Given this list of marker genes PDIA5, STK40, MED28, MYO1F, UBALD2, NDUFA7, ZBP1, CLCN1, IRF7, PIK3CD, GYPC, SIK3, OAS3, ZNF580, IP6K1, TTYH3 (NCBI Gene Id 80727), TMEM140, PLAC8, SERTAD3, C19orf53, NFATC2IP, PDE4B, MROH1, DNAJC7, PLAGL1, GTF3C5, DACT2, STX11, PRDX2, DSE, C1orf54, ARHGAP8, FBXO33, SPCS2, SRD5A3, TRAFD1, PAK1, PTGR1 (prostaglandin reductase 1), C9, SAA1, MCTP1, CHMP5, ADAM8, FES, CBLB, KIF13B, NDST1, USB1, PDLIM2, ENG, EVL, OTUD1, SLIT3, TMEM98, CYTH1, NBAS, ITM2C, F11R, TLR4, GCA, TAPBP, IFT22, DYNLT2B, NIT1, CDH15, TDRD7, RAB19, ITM2B, MSANTD1, IRGM, RBM43, KCNAB2, FYCO1, GMPPB, TBX21, IFNG, BLVRB, SH3BP2, IKZF2, SETDB2, STAT1, CA2, PARP8, RERE, STC2, PEX2, PTPRS, PRRC1, ZNF839, SMDT1 (single-pass membrane protein with aspartate rich tail 1), IL10RA, TLR2, IRF5, SERPINB6, PHF21A, HNRNPLL, ATOX1, IL18, SAMD12, LLGL1, OAS2, TNFSF11, C19orf38, DHX58, PARP14, AP1M2, ICOS, SOCS1, LGALS3BP, GPR18, CASP9, MOCOS, SLC9A1, NUB1, DPH5, HERC6, KCTD2, STK10, TP53BP1, SNAP47, CCL4, SPATA13, NT5C3A, MIEN1, CD86, CFAP36, NKG7, RIGI, LMCD1, WASF2, MAPKBP1, STX2, PRKCD, ATP8A1, ART5, CSF1 (NCBI Gene Id 1435), DDX60, MPPED1, QPRT, ADIPOQ, HMGA2, GCHFR, NCOA7, DTX3L, ISG20, SHFL, PCBD1, HOXB3, GNG2, RESF1, ADAMTS8, CLEC6A, ERGIC3, ACOT8, ITGA4, RNASEL, LRRC74A, ZFPM1, SLC35B4, STAT2, SPATA6, ZNF513, IGHMBP2, ZNFX1 (zinc finger NFX1-type containing 1), C15orf40, TBRG1, TEX35, FCER1G, LAMTOR4, TJP2, CSF2, EPSTI1, BBS4, MAF, SAMHD1, RTP4, DRGX, P3H1, QNG1, CGAS, CMPK2, IL2RB, RSAD2, NACC2 (NACC family member 2), MTX1, ANXA1, CCRL2, ITPR1, TRAPPC1, CXCL13, SGCB, CST3, LYN, TRIM5, DYNC2LI1, NUP210L, FKBP15, NAT1, ASAH2, here is a description of the gene set: Human Gene Set: GSE41867_DAY15_EFFECTOR_VS_DAY30_EXHAUSTED_CD8_TCELL_LCMV_CLONE13_UP studied in species Homo sapiens During acute viral infections, naïve CD8+ T cells differentiate into effector CD8+ T cells and, after viral control, into memory CD8+ T cells. Memory CD8+ T cells are highly functional, proliferate rapidly upon reinfection and persist long-term without antigen. In contrast, during chronic infections, CD8+ T cells become “exhausted” and have poor effector function, express multiple inhibitory receptors, possess low proliferative capacity, and cannot persist without antigen. To compare the development of functional memory T cells with poorly functional exhausted T cells, we generated longitudinal transcriptional profiles for each. from publication Doering TA, Crawford A, Angelosanto JM, Paley MA, Ziegler CG, Wherry EJ (PMID 23159438) Genes up-regulated in CD8 T cells during chronic infection with LCMV-Clone 13: effectors at day 15 versus exhausted at day 30.